Given this list of marker genes L3MBTL1, NEO1, CASP3, LRTM2, TCHH, GPR20 (G protein-coupled receptor 20), ELN, RBM24, CCN5, RNF144B, CEACAM5, TRPV4, GJB4, MESP2, CRCT1, PTPN5, TMEM217, ADRB1, UCN, GDF6, MIR543, PCDHB13, CDH7, BLNK, VLDLR, LCE3B, PLA2G4E, TNMD, SSC4D, CTHRC1, ARHGAP36, GAREM1, SLC27A2, EGFR, TPD52, FGF18, LCN2, ANK2, TDRD12 (tudor domain containing 12), THNSL2, UIMC1, ZCCHC8, VWCE, PIWIL4, CTSLP3, RAB39A, RSPH6A, BTF3 (NCBI Gene Id 689), C1QL4, SPINT3, SYNPO, MIR130A, FAT1, COPS3, SLC28A3, DYSF, ACTRT3, GPIHBP1, SSTR3, ADAM9, CALHM1, MIR205, MSLNL, GJA4, DMPK, UNC45B, ZFR2, VSIG8 (V-set and immunoglobulin domain containing 8), MIR219A1, TSNAXIP1, MANSC1, SERPINB12, NEK1, MYH11, IL9 (NCBI Gene Id 3578), GABRB2, ARHGEF5, MIR551B, MSX1, SMOC2, DISC1, PRSS3P1, TMEM198, RPRM, KANK2, CYP51A1, GJC1, RAB15, NHLRC1, POLA1, HSD3B2, RAP2A, TCEAL8, TSPAN15, S1PR3, REM2, PIK3C2G, PTGDS, EFR3B, SYCP2, MGST1, DRD2, FBLN5, TNFRSF13C, XKR4, TTC36, IL6, FNBP1L, ACSF3, GNG11, FLG2, UNC5B, ARHGEF17, FKBP6, ENG, BPIFB1, KCNC1, CRHR1, KCNA1, RASAL2, ELFN1, GOLGA8A, FCGR2B, LRFN3, SOX10, PDZRN3, SDC4, LRFN4, NKPD1, JAG1, MIR448, AADAC, ANKFN1, KRTAP19-7, VPREB1, CRYAA, ADCYAP1, here is a description of the gene set: from publication Popov A, Driesen J, Abdullah Z, Wickenhauser C, Beyer M, Debey-Pascher S, Saric T, Kummer S, Takikawa O, Domann E, Chakraborty T, Krönke M, Utermöhlen O, Schultze JL (PMID 18802101) studied in species Homo sapiens Genes down-regulated in mature dendritic cells: stimulatory versus inhibitory treated by prostaglandin E2. Human Gene Set: GSE9946_MATURE_STIMULATORY_VS_PROSTAGLANDINE2_TREATED_MATURE_DC_DN Myeloid dendritic cells (DC) and macrophages play an important role in pathogen sensing and antimicrobial defense. Recently we demonstrated that infection of human DC with intracellular bacterium Listeria monocytogenes (L.monocytogenes) leads to the induction of the immunoinhibitory enzyme indoleamine 2,3-dioxygenase (Popov et al., J Clin Invest, 2006), while in the previous studies L.monocytogenes infection was associated with a rather stimulatory DC phenotype. To clarify this discrepancy we performed comparative microarray analysis of immature mo-DC (immDC), mature stimulatory mo-DC (matDC) and mature inhibitory DC either stimulated with prostaglandin E2 (PGE2-DC) or infected with L.monocytogenes (infDC). Studying infection of human myeloid DC with Listeria monocytogenes, we found out, that infected DC are modified by the pathogen to express multiple inhibitory molecules, including indoleamine 2,3-dioxygenase (IDO), cyclooxygenase-2, interleukin 10 and CD25, which acts on DC as IL-2 scavenger. All these inhibitory molecules, expressed on regulatory DC (DCreg), are strictly TNF-dependent and are in concert suppressing T-cell responses. Moreover, only DCreg can efficiently control the number of intracellular listeria, mostly by IDO-mediated mechanisms and by other factors, remaining to be identified. Analyzing publicly acessible data of transcriptional changes in DC and macrophages, infected by various pathogens and parasites (GEO, GSE360), we noticed that infection of these cells with Mycobacterium tuberculosis causes transcriptional response, comparable with the one caused by listeria in human DC. In fact, granuloma in tuberculosis and listeriosis in vivo are enriched for myeloid DC and macrophages characterized by regulatory phenotype. In summary, regulatory myeloid DC and macrophages may play a dual role during life-threatening granulomatous infections, such as tuberculosis: on one hand, regulatory myeloid cells promote pathogen containment by efficiently killing intracellular bacteria, on the other hand these cells inhibit granuloma-associated T cells and thereby might be involved in the retention of TNF-controlled granuloma integrity protecting the host from granuloma break-down and pathogen dissemination.